The following is a description of a gene set: studied in species Homo sapiens Human Gene Set: chr22q11, and this is the list of marker genes: FAM230A, ABHD17AP4, ENSG00000308374, BMP6P1, BCRP8 (BCR pseudogene 8), KLHL5P1, ENSG00000309048, IGLV3-22, LINC00528, IGLJ2, LINC02891, LRRC74B (leucine rich repeat containing 74B), TUBA3FP, CES5AP1, IGLVI-38, KLHL12P1, UFD1-AS1, PABPC1P9, IGLVIVOR22-1, IGLC3, ENSG00000278188, TPTEP1, PPIL2, MIR3198-1, CELSR1P1, PRAMENP, IGLV1-40, LINC01637, SLC25A15P5, SUSD2P2, IGKV2OR22-4, FBXW4P1, CA15P1, TOP3BP1, DDTL, IGLV2-28, FAM230G, IGLV3-30, ENSG00000206090, RN7SKP63 (RN7SK pseudogene 63), MED15P7, IGLV1-47, CCDC74BP1, ZNF280B, GGT2P, RAB36, USP18, IGLV4-60, YPEL1, IGLV2-8, IGLV10-67, MIR301B, ENSG00000236754, DUXAP8, RPL34P35, POM121L4P, ZNF402P, ACTR2P1, IGLV3-9, TBX1, GGT1, E2F6P1, PI4KAP2, POM121L7P, IGLV7-46, OR11H1, MIR5571, POM121L1P, ENSG00000282012, TOMM40P2, IGLV3-7, PIWIL3, FAM230B, ABCD1P4, IGLV3-16, RPS10P29, SCARF2, SEPTIN5, PPM1F, ADORA2A, KIAA1671-AS1, DGCR2, RN7SL280P (RNA, 7SL, cytoplasmic 280, pseudogene), GNB1L, ENSG00000233577, GGT5 (NCBI Gene Id 2687), E2F6P2, RNU6-816P, GP1BB, PRODH, FAM246B, DRICH1, DGCR8, FAM32BP, CLTCL1, SUSD2P1, MED15, FAM230H, ZNF74, ANKRD62P1-PARP4P3, RN7SKP221, SNORA77B, IGLVV-66, SLC9B1P4, SPECC1L-ADORA2A, IGLV3-15, ASH2LP1, PPP1R26P4, IGLJ6, KCNMB3P1, LINC02556, GRAMD4P2, IGLVI-63 (immunoglobulin lambda variable (I)-63 (pseudogene)), IGLVIV-66-1, HDHD5-AS1, UBE2L3, ADA2, IGLV3-24 (immunoglobulin lambda variable 3-24 (pseudogene)), LINC01311, IGLJ7, IGLV3-31, SLC25A18, LINC01665, TSSK2, DDT, TMEM191C, SDF2L1, IL17RA, RANBP1, IGLV2-14, ENSG00000304096, RIMBP3, IGLV3-4, IGLV5-45, SOCS2P2, ENSG00000297197, BNIP3P2, TUBA8 (NCBI Gene Id 51807), MIR649, BCRP3 (NCBI Gene Id 644165), SERPIND1, SLC9A3P2, MIR130B, SGSM1, RPS10P30, LINC01634, PRAME, DGCR6, CCDC116, MMP11, PPM1F-AS1, RIMBP3C, VWFP1, ATP5PFP2 (NCBI Gene Id 100293860), IGLV3-1, VPREB1, LINC01651, MIR650, IGLV2-5, IGLV8-61, UFD1, ARHGAP42P3, SLC7A4, CA15P2, BID, BCL2L13, E2F6P3, FAM230F, MIR6817, UPB1, VPREB3, PPP1R26P5 (NCBI Gene Id 100133040), ARVCF, POM121L15P, IGLC1, ARL5AP4, IGLVVI-22-1, NBEAP3, LINC00895, NEK2P2, IGKV2OR22-3, TERF2IPP1, PCAT14, MIR3618, RNU6-225P, IGLV3-29, FABP5P11, CHCHD10, AIFM3, RIMBP3B, ATP6V1E1, CRYBB2, IGLV3-10, TSSK1A, IGLV3-26, RN7SL843P (RNA, 7SL, cytoplasmic 843, pseudogene), SPECC1L, CECR9 (cat eye syndrome chromosome region, candidate 9), GSTT3P (glutathione S-transferase theta 3, pseudogene), IGLC2, TANGO2, SNAP29, IGLC7, PRODHLP, CABIN1, SMARCB1, ABHD17AP5, IGLV1-62, ARL2BPP10, ASH2LP3, CECR3, BCR, GAB4, TMEM121B, IGLV9-49, MIR1286, ENSG00000284294, RGL4, IGLV5-52, BCRP4, FAM230D, PSLNR, RTL10, TOP3B, LINC01664, IGLV3-2, IGLVI-70, P2RX6, ZDHHC8BP, THAP7-AS1, RNU6-458P, KRT18P62, ENSG00000252020, IGLV2-11, FAM230I, IGLC4, GUSBP11, ZNF280A, FAM246C, IGLV6-57, POTEH-AS1, HIRA, GSTT2B, CCDC188, IGLV3-17, IGLJ1, FAM230J, POTEH, IGLV5-48, IGLV7-35, IGLV4-69, GGT3P, LINC02557, RN7SL812P, IGLVIV-65, GGTLC5P, SLC2A11, CCDC188BP, FAM246A, IGLV2-23, IGLVI-56, C22orf15, IGLVIV-53, IGLVI-42, IGLV1-44, GNAZ, IGKV1OR22-1, IGLV2-18, SLC25A1, ANKRD62P1, IGLV3-19, ENSG00000275635, BMS1P22, PPP1R26P3, CECR2, TXNRD2, USP41P, HIC2, KIAA1671, CRIP1P4, IGLJ5, BCRP5, STMN3P1, CRKL, PHF10P2, ACTR3BP6, IGLV2-34, RPL8P5, IGLJ3, RN7SL268P, IGLV3-12, ZNF70, IGLV11-55, TMEM191B, P2RX6P, IGLV1-36, MIR185, IGLV3-21, FAM230E, IGLV3-27, LINC01659, IGLV3-25, ADORA2A-AS1, PPP1R26P2, NF1P6, IGLL1 (NCBI Gene Id 8222), TRMT2A, SUSD2, ENSG00000288811, IGLL3P (immunoglobulin lambda like polypeptide 3, pseudogene), PI4KAP1, FAM247B (family with sequence similarity 247 member B), VN1R9P, CCT8L2, LRP5L, LRRC75B, PEX26, MRPL40, LZTR1, GSC2, PARP4P3, POM121L10P, RNA5SP493, RPL28P6, MIF, HSFY1P1 (NCBI Gene Id 27437), MIR1306, MIF-AS1, RPL31P62, ENSG00000252143, IGLVI-68, C22orf39, TUBA3GP, RN7SL168P, SSBP3P3, IGLV3-32, MPPE1P2, GGTLC2, CRYBB2P1, YME1L1P1 (YME1L1 pseudogene 1), ESS2, RPL32P5, XKR3, SNRPD3, IGLC5, IGLV1-51, GUCD1, ENSG00000199783, RTN4R, CHEK2P4, IGLV3-6, CECR7, THAP7, IGLV5-37, IGLC6, CLCP1, IGLVI-20, IGLV10-54, ASLP1, ZNF72BP, RN7SKP131, CDC45, KLHL22, RN7SL263P, RNY1P9, ASH2LP2, IGKV1OR22-5, GSTT4, IGLL5, USP10P3, DGCR11, IGLJ4, DNAJA1P6, RHEBP3 (RHEB pseudogene 3), PI4KA, GGTLC4P, GGTLC3, MICAL3, LL22NC03-63E9.3, ZDHHC8, ENSG00000274625, MAPK1, IGLVVII-41-1, FAM247A, IGLV4-3, IGLV3-13, LHFPL7, ENSG00000207751, BCRP2, IGLV1-50, CLDN5, YDJC, IGLVVI-25-1 (immunoglobulin lambda variable (VI)-25-1 (pseudogene)), ASH2LP4, DGCR5, MIR4761, TMEM191A, GPM6BP3, IL9RP6, MIR6816, BCRP7 (NCBI Gene Id 100420102), IGLVIV-59, CRYBB3, RSPH14, DERL3, IGLV2-33, IGLL4P, BCRP6, POM121L9P, SMPD4P1, IGLVIV-64, IGLVV-58, IGLV7-43, KRT18P5, COMT, LINC00896, POM121L8P, IGKV3OR22-2, BMS1P20, GSTT2, MIR648, MTND1P17, RPL7AP70, BCRP1, IGLV1-41 (NCBI Gene Id 28824), HDHD5, DGCR6L